The following is a description of a gene set: species: Mus musculus The process in which the structure and material content of mature peripheral nervous system myelin is kept in a functional state. Mouse Gene Set: GOBP_PERIPHERAL_NERVOUS_SYSTEM_MYELIN_MAINTENANCE, and this is the list of marker genes: Prx, Fa2h, Ndrg1, Sod1, Akt1, Akt2, Plec, Pals1, Sh3tc2